The following is a description of a gene set: Mouse Gene Set: GOMF_POLY_PURINE_TRACT_BINDING Binding to a stretch of purines (adenine or guanine) in an RNA molecule. species: Mus musculus, and this is the list of marker genes: Patl2, Pnpt1, Slirp, Pabpc1 (poly(A) binding protein, cytoplasmic 1), Pabpn1l (NCBI Gene Id 382035), Ppie, Khdrbs1, Pan3, Mcrs1, Khdrbs2, Zc3h14, Pabpc6, Pabpc5, Paip2b, Larp4, Elavl4, Pabpn1, Eif4a3, Rbms2, Dazap1, Rbms3, Ddx1, Ddx3x, Eif4a3l2, Atxn1, Pabpc4, Patl1, Syncrip, Fmr1, Hnrnpdl, D1Pas1, Pabpc2, Paip2, Rbms1, Eif4a3l1, Hnrnpu, Pabpc4l (NCBI Gene Id 78704), Pabpc1l